Given this list of marker genes Kcnk4, Tmem150c, Nalf2, Tmem63b, Trpv4, Nalf1, Kcnk2, Piezo1, here is a description of the gene set: Enables the transmembrane transfer of a monoatomic cation by a channel that opens in response to a mechanical stress. studied in species Mus musculus Mouse Gene Set: GOMF_MECHANOSENSITIVE_MONOATOMIC_CATION_CHANNEL_ACTIVITY